The following is a description of a gene set: Mouse Gene Set: GOBP_CELLULAR_RESPONSE_TO_NICOTINE species: Mus musculus Any process that results in a change in state or activity of a cell (in terms of movement, secretion, enzyme production, gene expression, etc.) as a result of a nicotine stimulus., and this is the list of marker genes: Ntrk1, B2m, Chrna5, Rela, Th, Kcnj11, Nfkb1, Bad, Chrna2, Tnf